Given this list of marker genes NOTCH1, TGFBR3, MIR1-1 (NCBI Gene Id 406904), SPRED1, TBX5, here is a description of the gene set: Human Gene Set: GOBP_VASCULOGENESIS_INVOLVED_IN_CORONARY_VASCULAR_MORPHOGENESIS The differentiation of endothelial cells from progenitor cells that contributes to blood vessel development in the heart, and the de novo formation of blood vessels and tubes. studied in species Homo sapiens